The following is a description of a gene set: The sex chromosome present in both sexes of species in which the male is the heterogametic sex. Two copies of the X chromosome are present in each somatic cell of females and one copy is present in males. Mouse Gene Set: GOCC_X_CHROMOSOME studied in species Mus musculus, and this is the list of marker genes: Smchd1, Pcgf5, H2az1, Xist (inactive X specific transcripts), Macroh2a1, Pcgf3, Cdk2, Macroh2a2, H3f3a, Lrif1, Sin3b